The following is a description of a gene set: studied in species Homo sapiens Human Gene Set: GOBP_REGULATION_OF_SYNAPTIC_PLASTICITY A process that modulates synaptic plasticity, the ability of synapses to change as circumstances require. They may alter function, such as increasing or decreasing their sensitivity, or they may increase or decrease in actual numbers., and this is the list of marker genes: SLC1A1, LRRTM1, STX4, SHANK2, RELN, INS, SRF, GIPC1 (GIPC PDZ domain containing family member 1), PICK1, HRAS, SLC24A2, STAU1, PLK2, GRID1, ADORA1, ARF1, RAB5A, STX3, FXR1, GRIN2C, CAMK2G, FAM107A, ACP4, RASGRF2, ADCY8, MIR337, EIF4EBP2, GFAP, CPEB3, RAC1, CHRDL1, KCNQ3, NPAS4, SYP, CDC20, UNC13C, MIR320B1, APOE, NETO1, GSG1L, SYNGAP1, MIR541, CALB2, KAT2A, CAMK2B, MIR342 (NCBI Gene Id 442909), NOG, CFL1, SQSTM1 (NCBI Gene Id 94002), BRAF, LZTS1, TYROBP, DBN1 (drebrin 1), SHISA6, LGMN, ABHD6, CAMK2A, PTN, GRM5, TNR, PRNP, SERPINE2, ZDHHC2, CLN3, MAPT, P2RX3, MAPK1, YTHDF1, CHRNA7, VAMP2, PRKCZ, CD2AP, SYT4, MEF2C, RAB3A (NCBI Gene Id 96387), UBE3A, PENK, JPH4, CALM3, RAPGEF2, GRIA3, HMGCR, AGER, MIR320D1, LILRB2, DRD5, MCTP1, GRM2, CNTN2, RASGRF1, ADORA2A, RAB11A, SLC4A10, CDK5, MIR433, NEUROD2, JPH3, MIR320E, NF1, SHISA8, NCDN, CPLX2, AKAP5, PPFIA3, SORCS3, MIR30B, CRHR2, SCT (secretin), MAP1B, GRIN2A, CALM1, RAB8A, ANAPC2, CRH, RARA, IQSEC2, MIR324, F2R, SYAP1, RGS14, SORCS2 (sortilin related VPS10 domain containing receptor 2), PPP3CB, KCNB1, SSH1, SYNGR1, SIPA1L1, NSMF, SLITRK4, MIR320C1, GRIN2D, ADCY1, CAMK2D, SNAP25, MECP2, PRKAR1B, ITPR3, KMT2A, GRID2IP, GRIN2B, MIR320D2, BAIAP2, PTK2B, NTRK2, CALHM2, APP, MIR320A, YWHAH, C22orf39, SLC8A2, NSG1, GRIN3A, PRRT1, KIT, GRIN3B, DRD1, CALM2 (calmodulin 2), SYT7, FMR1 (fragile X messenger ribonucleoprotein 1), DAG1, SHANK3, VPS13A, NR2E1, SCTR, GSK3B, RAB3GAP1, PSEN1, FXR2, ARC, BEST1, MAP1A, SLC8A3, CX3CR1, PDE9A, CYP46A1, ACE, SYT12, BRSK1, SLC18A3, GRIN1, CREB1, HRH1, ABL1, MIR545, KCNJ10, ITPKA, DRD2, SHISA7, NCSTN, CBLN1, EPHA4, SLC24A1, YWHAG, TSHZ3, EIF2AK4, MIR421, EPHB2, IGSF11, CD38, ATF4, STAU2, MPP2, SLC38A1, LARGE1, DLG4 (discs large MAGUK scaffold protein 4), SHISA9, NPTN, MIR320C2, PRRT2, MIR95, CX3CL1, PRKCG, KRAS, ADGRB1, S100B, NEURL1, CALB1, STXBP1 (NCBI Gene Id 6812), SNCA, PAIP2, MIR320B2, GRIK2, CNTN4, MME, GRIA1, NFATC4, NRGN, LRRTM2, GRID2, VGF